The following is a description of a gene set: Mouse Gene Set: GOBP_RESPONSE_TO_CAFFEINE studied in species Mus musculus Any process that results in a change in state or activity of a cell or an organism (in terms of movement, secretion, enzyme production, gene expression, etc.) as a result of a caffeine stimulus. Caffeine is an alkaloid found in numerous plant species, where it acts as a natural pesticide that paralyzes and kills certain insects feeding upon them., and this is the list of marker genes: Irs1, Chek1, Fkbp1a, Cad, Slc8a1, Adora2a, Tmem38b, Prkaa1, Ryr2, Casq2, Ryr1, Prkaa2, Gstm7, Gnal, Selenon, Ryr3, Tmem38a, Cacna1s, Prss2